Given this list of marker genes Rin3, Vegfb, Ccl5, Vegfa, Rac2, Swap70, Vegfc, Vegfd, Pgf, here is a description of the gene set: studied in species Mus musculus Any process that modulates the rate, frequency or extent of mast cell chemotaxis. Mast cell chemotaxis is the movement of a mast cell in response to an external stimulus. Mouse Gene Set: GOBP_REGULATION_OF_MAST_CELL_CHEMOTAXIS